Given this list of marker genes OTUB1, BDKRB2, DNPH1, OGFR, SYNGR2, ABLIM1, SUPT5H, KCNAB2, UBE2M, CTRL, CYC1, HDGF, IGFBP2, LCK, AURKB, IDH3B, ZNF148, ZNF593 (zinc finger protein 593), KXD1, SF3A2, ZKSCAN8, PKM, MED24, UQCRQ, CUL5, RGL1, NUP62, RER1, JTB, LSM12, POMK, RAD54L2, TFF2, STK11, GUK1, KAT5, KCNH2, MAU2, TAF6L, EEF1A2, CASR, MPHOSPH9, AHCYL1, JAK3, MLF2, SLC2A5, CLPTM1, TCF25, ERP44, CCNF, UQCR11, ERCC1, GLS2, RBM42, PDAP1, AIP, ZBED1, RGP1, SORL1, ARHGDIA, UBTF, SYMPK, OSM, MRPL58, NDUFV1, MASP2, YWHAE, LPCAT1, NPIPA1, RAD23A, SUPT6H, NFATC2IP, KDM5C, RALA, BRD3, NCOR2, PKD1, UBE2S, TMED9, RNF8, BBLN, CABIN1, BCR, NUP50, MAP4, CSNK2A1, TP53, ZFP36L2, MAZ, P4HB, ZFTRAF1, PSMD11 (NCBI Gene Id 5717), MAST1, PPP2R1A, MED6, ADA, PURA, HGS, MTF1, PRPF19, TMEM109, PPP5C, CSNK2B, EIF4A1, RNH1, NKTR, here is a description of the gene set: Cluster 2: genes up-regulated in B493-6 cells (B lymphocytes) by serum alone or in combination with MYC but not by MYC alone. studied in species Homo sapiens Human Gene Set: SCHLOSSER_SERUM_RESPONSE_AUGMENTED_BY_MYC Proliferation of higher eukaryotic cells is triggered by the proto-oncogene c-myc (myc), which is induced downstream of a large number of growth factor receptors. Myc, a basic helix-loop-helix leucine zipper transcription factor, transmits growth signals by up- and downregulation of target genes. The importance of Myc in growth control is well established. However, the number of growth control genes requiring Myc as an essential factor for regulation after mitogenic stimulation of cells is not yet clear. Here, we have studied the transcriptional programme of a human B-cell line, P493-6, in response to Myc and serum. P493-6 cells do not express the endogenous myc, nor is it induced by serum stimulation. Proliferation of the cells is dependent upon both the expression of a tetracycline-regulated myc gene and serum stimulation. Using DNA microarrays, expression profiling was performed following stimulation of cells with serum, with Myc, or with both. We observed serum regulation of >genes. A number of these genes were synergistically or antagonistically regulated by Myc. Moreover, we identified >300 Myc-regulated genes that were almost unresponsive to serum. Gene ontology analysis revealed that a high proportion of Myc target genes are involved in ribosome biogenesis and tRNA metabolism. The data support our current notion that Myc is essential for the regulation of a large number of growth-related genes in B cells, and cannot be replaced by other serum-induced factors. from publication Schlosser I, Hölzel M, Hoffmann R, Burtscher H, Kohlhuber F, Schuhmacher M, Chapman R, Weidle UH, Eick D (PMID 15516975)